Given this list of marker genes ABCB1, PON3, PON1, SLCO2B1, UGT1A3, CYP3A4, SLCO1B1, SLCO1B3, ABCC2, here is a description of the gene set: Atorvastatin (ATV, brand name Lipitor), is a lipid-lowering drug of the statin class of medications. It inhibits the endogenous production of cholesterol in the liver, thereby lowering abnormally high cholesterol and lipid levels, and ultimately reducing the risk of cardiovascular disease. Statins inhibit the enzyme hydroxymethylglutaryl-coenzyme A reductase (HMGCR), which catalyzes the critical step in cholesterol biosynthesis of HMG-CoA conversion to mevalonic acid. Statins are the most commonly prescribed medication for treating abnormal lipid levels (Malhotra & Goa 2001). ATV and its hydroxy-metabolites collectively inhibit HMGCR to reduce circulating low-density lipoprotein cholesterol. <br><br>ATV is transported in the blood almost exclusively bound to plasma proteins (>98%), and is subject to pre‑systemic clearance at the gastrointestinal tract and to first‑pass hepatic clearance, which explains its low systemic bioavailability (~12%). Organic anion transporters OATP1B1, OATP1B3 and OATP2B1, encoded by SLCO1B1, SLCO1B3, and SLCO2B1, respectively are expressed on the sinusoidal membrane of hepatocytes and can facilitate the liver uptake of drugs such as ATV (Kalliokoski & Niemi 2009).<br><br>In hepatocytes (and to a lesser extent, the GI tract), ATV can be hydroxylated by cytochrome P450 3A4 (CYP3A4) to hydroxy-metabolites, or undergo lactonization via an unstable acyl glucuronide intermediate to ATV lactone (ATVL) mediated by UGT1A3 and 1A1. ATVL may also be hydroxylated by CYP3A4 to hydroxylactone-metabolites. The lactone metabolites are inactive against HMGCR, but can be hydrolyzed via paraoxonases (PONs) to their corresponding hydroxy acids, which are active against HMGCR. Elimination of ATV and its metabolites is principally biliary with apparently no significant enterohepatic recirculation. Half-life (t1/2) is approximately 14 h for atorvastatin and 20–30 h for its metabolites. species: Homo sapiens part of: Drug ADME Reactome Pathway: Atorvastatin ADME